The following is a description of a gene set: species: Mus musculus Behavior that is dependent upon the sensation of chemicals. Mouse Gene Set: GOBP_CHEMOSENSORY_BEHAVIOR, and this is the list of marker genes: Lmx1a, Prkcg, Ntrk1, Mrgpra3, Grin1, Taar4, Drd4, Atp6v1b1, Cfap69, Mrgprx1, Ubr3, Lmx1b, P2rx3, Scn9a, Adcy3, Prkce, Scn11a, Wfs1, Shank1, Mup20, Adam11, Gucy2d, Bbs1, Tpbg, Gjb4, Chd7